The following is a description of a gene set: Mouse Gene Set: GOBP_CEREBELLAR_GRANULAR_LAYER_DEVELOPMENT The process whose specific outcome is the progression of the cerebellar granule layer over time, from its formation to the mature structure. The granular layer is the innermost layer of the cerebellar cortex. This layer contains densely packed small neurons, mostly granule cells. Some Golgi cells are found at the outer border. Granule neurons send parallel fibers to the upper molecular layer, where they synapse with Purkinje cell dendrites. Mossy fibers from the pontine nuclei in the white matter synapse with granule cell axons, Golgi cell axons and unipolar brush interneuron axons at cerebellar glomeruli in the granule cell layer. studied in species Mus musculus, and this is the list of marker genes: Faim2, Wnt7a, Nrxn1, Ulk1, Grid2, Prox1, Atp2b2, Mdk, Cend1, Cbln1, Mtpn, Ttbk2, Kif14, Nfix, Kndc1, Serpine2, Ophn1